The following is a description of a gene set: studied in species Homo sapiens Neighborhood of TM4SF2 Human Gene Set: GNF2_TM4SF2 Neighborhood of TM4SF2 NULL in the GNF2 expression compendium, and this is the list of marker genes: STXBP1, SV2A, SYN1, RALYL, NMNAT2, FAIM2, NAP1L2, BSN, PHYHIP, DIRAS2, RUNDC3A, SV2B, TSPAN7, SH3GL2 (NCBI Gene Id 6456), DNM1, TAGLN3, PGBD5, CLIP3, SLC12A5, HPCAL4, ATP2B2, SNAP91, KIF3C, GNAO1, SNAP25, CA11